Given this list of marker genes Stra8, Ankk1 (ankyrin repeat and kinase domain containing 1), Mef2c, Epha3, Ltk, Htra2, Mir3099, Meiosin, Tead2, Atm, Gsk3b, Brinp2, Pax2 (paired box 2), Phc1, Klf4, Abca1, Add1, Serpinf1, Tescl (tescalcin-like), T, Snw1, Abl2, Rara (retinoic acid receptor, alpha), Osr1, Brinp1, Twf2, Ptk2b (NCBI Gene Id 211703), Cyp26a1, Slc6a4 (solute carrier family 6 (neurotransmitter transporter, serotonin), member 4), Tnc, Ptk6, Sox9, Aqp1, Gjb3, Hoxa2, Rxrb, Ret, Hand2, Rarg, Hoxa1, Drd2, Halr1, Tnf, Yap1, Col1a1, Phb2, Rhox13 (reproductive homeobox 13), Aldh1a2, Lyn, Krt13, Yes1, Ptk7, Tead1, Cyp26b1, Creb1, Lep, Brinp3, Tesc, Ccl2, Tbx1, Pck1 (phosphoenolpyruvate carboxykinase 1, cytosolic), Rorb, Ndufa13, here is a description of the gene set: Any process that results in a change in state or activity of a cell (in terms of movement, secretion, enzyme production, gene expression, etc.) as a result of a retinoic acid stimulus. Mouse Gene Set: GOBP_CELLULAR_RESPONSE_TO_RETINOIC_ACID species: Mus musculus